Given this list of marker genes CCL2, C4B, C3, ABCA7, TGM2, HMGB1, C2, CD300LF, C4A, TREM2, here is a description of the gene set: studied in species Homo sapiens Any process that modulates the frequency, rate or extent of apoptotic cell clearance. Human Gene Set: GOBP_REGULATION_OF_APOPTOTIC_CELL_CLEARANCE